The following is a description of a gene set: studied in species Homo sapiens Human Gene Set: CUI_DEVELOPING_HEART_LEFT_ATRIAL_CARDIOMYOCYTE from publication Cui Y, Zheng Y, Liu X, Yan L, Fan X, Yong J, Hu Y, Dong J, Li Q, Wu X, Gao S, Li J, Wen L, Qiao J, Tang F (PMID 30759401), and this is the list of marker genes: PITX2, GPX3, FHL1, COL2A1 (collagen type II alpha 1 chain), PIM1, CIMAP3, NR2F1-AS1, SFRP1, RELN, BCO2, TESC, CALB2, MYH6, GJA5, RABGAP1L, VSNL1, CLIC5, NR2F1, PAM